Given this list of marker genes DFFA (NCBI Gene Id 1676), NONO, SALL3, BOK (NCBI Gene Id 84558), PRKCA, SLC9A5, EMX2, ADGRG2, NKAPL, MEIOSIN, DNPH1, CARD6, FAM53C, KNOP1, TAL1, ZNF219, TRERF1, FAM168A, NID1, EBAG9, LRCH4, PNOC, NR2E3, HSD17B12, XRCC4, ACO2, FGF13, CMBL (carboxymethylenebutenolidase homolog), DAB2, BET1, FBXO4, REXO1, TP53INP2, GPAT3, SMG7, ZMYND11, TPM3, ARHGAP1, IL1RN, ASIC4, ABHD4, RNGTT, ERCC6L2, GNG13, CETN1, KLHL18, ST3GAL1, TRIM55, PRPS2, SMLR1, GAS7, FAM120A, FBXL16, UBE3A, VSIG10, here is a description of the gene set: Human Gene Set: MIR4489 from publication Chen Y, Wang X (PMID 31504780) studied in species Homo sapiens Genes predicted to be targets of miRBase v22 microRNA hsa-miR-4489 in miRDB v6.0 with MirTarget v4 prediction scores > 80 (high confidence targets).